The following is a description of a gene set: species: Homo sapiens Any process that modulates the frequency, rate or extent of the directed movement of a neurotransmitter into a neuron or glial cell. Human Gene Set: GOBP_REGULATION_OF_NEUROTRANSMITTER_UPTAKE, and this is the list of marker genes: DRD3, FLOT1, SLC17A8, ATP1A2, NOS1, ITGB1, TOR1A, PRKN, SYNGR3, RAB3B, PER2, GFAP, DRD2, DRD1, SNCA, ITGB3, DRD4, APP, GDNF (glial cell derived neurotrophic factor), GPM6B